The following is a description of a gene set: species: Homo sapiens Hepatosplenomegaly Human Gene Set: HP_HEPATOSPLENOMEGALY Simultaneous enlargement of the liver and spleen., and this is the list of marker genes: IL2RA, AP3B1, STEAP3 (NCBI Gene Id 55240), IL7R, DLK1, CALR, DNASE2, GNB2 (G protein subunit beta 2), KPTN, ALMS1, COG4, DZIP1L, JAK2, IARS1, ASAH1, TMEM67, SOX10, DPM1, IFIH1, RTL1, HAVCR2, RAG2, GCLC, PTPRC, TET2, SNX14, MPL, LSM11, SCYL1, JAK1, ZAP70, PEX2, CDKN2A, RUNX1, RAC2, ADAR, CD3D, LPL, PTPN2, STAT1, TNFSF11, SCARB2, NHLRC2, CTSK, VPS11, LYST, NEU1, IKBKG, PKHD1, TGFB1, RNASEH2A, TCF4, ASXL1, RNASEH2B, LPIN2, SLC4A1, CYBC1, TFE3, LIPA, GBE1, ZNF699, IL2RB, MECOM, NCKAP1L, PIK3CG, PIGA, PTPN22, MED12, IDS, PALLD (NCBI Gene Id 51653), KLF1, MAN2B1, COG1, GLRX5, TALDO1, GNE, SLC29A3, BRCA2, DDRGK1, TREX1, HBB, FARSA, GPR35, SLC2A1, SP110, MST1, RAB27A, CD247, RAG1, STXBP2, RNU4ATAC, IFNG, PEX13 (NCBI Gene Id 5194), CAV1, CCDC115, G6PC3, IL6ST, ADA2, SAMHD1, NLRP3 (NLR family pyrin domain containing 3), FCGR2A, PHEX, LBR, SMAD4, RHCE, RHD, RNASEH2C, BRCA1, RNU7-1, CD70, UNC13D, ZNFX1, ANKRD55, PRKCD, MEG3, SEMA4D, IDUA, DCDC2, ABCA1, MOGS, FGFR2 (NCBI Gene Id 2263), STAT4, PSTPIP1, COG5, CBL, COG7, RBM8A, CYP7B1, RASGRP1, SLC25A13, LYN, RABL3, CD3E, TULP3, OSTM1, SRSF2, RHAG, ABCA12, CLCN7, PALB2, GLB1, CA2, ITCH, MVK, SLC7A7, KIF3B, JAK3, GALK1, IFT140, STAT3, PRF1, TCIRG1, NPHP3, CD27, TP53, FERMT3 (FERM domain containing kindlin 3), GBA1, VPS33A, CTSA, KRAS, HEXB, IFNGR1, PLEKHM1, CFTR, GNPTAB